Given this list of marker genes FXN, SAV1, KCNK2, YY1, TOMM70, PPARA, CTDP1, NOG, CAV3, SLC6A4, RGS2, GSK3A, RGS4, CGA, MIR199A1, MIR873, WWC3, G6PD, MIR17HG, MIR25, MIR199B, PTEN, PI16, WWC2, TBX5, JARID2 (NCBI Gene Id 3720), MAPK11, FOXP1, TP73, MIR1-1, STK4, MIR200B, PAK1, RBP4, VGLL4, WWC1, STK3, here is a description of the gene set: Any process that stops, prevents, or reduces the frequency, rate or extent of growth of an organ of an organism. Human Gene Set: GOBP_NEGATIVE_REGULATION_OF_ORGAN_GROWTH studied in species Homo sapiens